Given this list of marker genes ZNF703, SLC30A4, ZFP36L1, TOP1, EFNB2, NCOA6, ILF3, RAB18, SLC20A1, PAG1, UBE2N, IL1RN, CXCL2, YTHDC1, TNFSF9, CD86, MAP3K8, MMP13, SRY, CD83, SCAMP1, ATP6AP1, IL1RL1, RREB1, CTPS1, GTF2E2, EEA1, NR4A1, ANKRD28, TNF, SMAD6, ERRFI1, DSTN, MYC, EGR1, EIF5, BHLHE40, PPIC, TNFAIP8, SPIN1, COL5A2, PDGFA, SELP, SARAF, CXCL3, LDAF1, PIM1, ATF4, RIOK3, MFSD14A, WTAP, GJA1, CPEB2, TXNRD1, HSPD1, PRNP, FRRS1, MAP2K4, DDX3Y (NCBI Gene Id 8653), MARCHF7, CRABP2, PPP1CB, KRAS, RHOB, NMD3, ANGPTL2, SERPINB2, ACSL4, PHLDA1, ICAM1, ARIH1, GMFG, CXCL9, TNFAIP2, NDEL1 (nudE neurodevelopment protein 1 like 1), JUNB, ZFP62, ABRACL, CPE, IL1B, LRRC58, FBLN2, TMC6, SQSTM1, CLCN4, AK1, CD14, IL1A, UTP4, KDELR3, SOCS2, PTEN, CCL7, MCOLN2, ATP6V1H, RAB3IL1, EPC1, PGM2 (phosphoglucomutase 2), TAX1BP1, INHBA, NFE2L2, EEIG1, SEPTIN2, GADD45B, MRAS, PPP1R15A, HNRNPR, MARCKSL1, CCL13, DUSP1, BTG2, MYL4, PTGS2, PELI1, SOCS3, TGIF1, CRKL, PLAUR, SMARCA2, RHOQ, NUPR1 (NCBI Gene Id 26471), SERPINH1, DDX5, PDE8A, SRSF11, ID1, ARIH2, CASP4, SERTAD1, XPOT, DNAJA1, MADCAM1, VCL, IL4R, FOS, SGK1, COL1A2, EI24, STT3B, EGR2, ZFP36, COL6A1, UBE2D3, CDKN1A, IL10, MDM2, IRF1, PPP3CA, CSRP1, NFKBIA, PROCR, DUSP2, UGDH, DLD, SMIM7, PIK3CA, PRDM1, SERPINE1, NFKBIZ, IFRD1, HNRNPK, CSNK1A1, TANK, ZNF644, JAK2, GPC4, ETF1, MOB1B, GTPBP4, LIN7C, SLC25A17, MIDN, B4GALT3, STX3, LCP2, STK40, UGCG, DNAJB6, IER2, TRA2B, BTG3, DOC2B (NCBI Gene Id 8447), ACOD1, HSP90AA1, IST1, ETS2, ATP13A3, MTDH, CLEC4E, RELB, DNAAF10, GDPD3, HMGA2, EHD1, KCTD12, RBM18, CLEC4D, LPAR1, SRGN, BIRC3, here is a description of the gene set: species: Homo sapiens Human Gene Set: GSE27434_WT_VS_DNMT1_KO_TREG_DN We investigated the role of DNMT1 in immune homeostasis by generating mice lacking DNMT1 in Foxp3+ T-regulatory (Treg) cells. These mice showed decreased peripheral Foxp3+ Tregs, complete loss of Foxp3+ Treg suppressive functions in vitro and in vivo, and died from autoimmunity by 3-4 weeks unless they received perinatal transfer of wild-type Tregs that prolonged their survival. Methylation of CpG-sites in the TSDR region of Foxp3 was unaffected by DNMT1 deletion, but microarray revealed more >500 proinflammatory and other genes were upregulated in DNMT1-/- Tregs. CD4-Cre-mediated DNMT1 deletion showed inability of conventional T cells to convert to Foxp3+ Treg under appropriate polarizing conditions. Hence, DNMT1 is absolutely necessary for maintenance of the gene program required for normal Treg development and function. Genes down-regulated in T reg: wildtype versus DNMT1 knockout. from publication Wang L, Liu Y, Beier UH, Han R, Bhatti TR, Akimova T, Hancock WW (PMID 23444399)